The following is a description of a gene set: Mouse Gene Set: GOBP_RRNA_PROCESSING species: Mus musculus Any process involved in the conversion of a primary ribosomal RNA (rRNA) transcript into one or more mature rRNA molecules., and this is the list of marker genes: Rps24, Ddx17, Nop53, Rpl27, Nol8, Trmt112, Mettl16 (methyltransferase 16, N6-methyladenosine), Ddx21, Mrm1, Prkdc, Nhp2, Utp14a, Wdr74, Rpl35, Ddx49, Pop5, Rpp30, Rcl1, Ncl, Emg1, Mrm2, Wdr46, Rpusd1, Dkc1, Zcchc4, Mettl15, Pa2g4, Rps15, Ddx56, Rpp25 (ribonuclease P/MRP 25 subunit), Rexo1, Esf1, Riok3, Wdr12, Dimt1, Mphosph6, Slx9, Tfb1m, Nop14, Rps27, Rps21, Abt1, Rps28, Rpl14, Wdr36, Rpl7l1, Exosc6, Dicer1, Tsr3, Pes1, Tsr1 (TSR1 20S rRNA accumulation), Wdr75 (WD repeat domain 75), Gtf2h5, Eif6, Pdcd11, Znhit3, Rpf2, Rps6-ps4, Heatr1, Rpp38, Utp15, Pwp1, Rps27rt, Wdr3, Ngdn, Rps16, Naf1, Fcf1, Rexo5, Nop9, Exosc8, Nsun4 (NCBI Gene Id 72181), C1d, Ddx51, Imp4, Rpl5, Gtpbp4, Rpf1, Tfb2m, Nop2, Rpp40, Ddx52, Pwp2, Rexo4, Exosc3, Tsr2, Mterf4, Rps25, Myg1, Drosha, Kat2b, Ak6, Mettl5, Exosc5, Npm3, Rpusd4, Isg20, Utp4, Riok1, Nol9, Rrp1, Pop7, Bop1 (NCBI Gene Id 97992), Ddx54, Ftsj3, Rnasel (NCBI Gene Id 353203), Rpusd2, Rps8, Mak16, Sde2, Mphosph10, Utp11, Bud23, Nat10, Fbll1, Riok2, Trmt2b, Bms1, Rps19, Ddx47 (DEAD box helicase 47), Pin4, Exosc1, Wdr55, Nsun5, Wdr43, Chd7 (chromodomain helicase DNA binding protein 7), Eri1, Utp14b, Exosc4, Utp23, Imp3, Utp3, Dis3, Pih1d2, Pak1ip1, Znhit6, Rbfa, Dhx37, Pih1d1, Mtrex, Rrp1b, Rrp9, Ybey, Nsa2, Krr1 (KRR1, small subunit (SSU) processome component, homolog (yeast)), Snu13, Gar1, Mrm3, Rpl11, Nol10, Sart1, Rpl7a, Nob1, Rps14, Rrp7a, Rrp15, Ddx10, Rps17, Utp6, Rrp36, Dcaf13, Exosc10, Lyar, Wdr18 (WD repeat domain 18), Utp25, Ythdf2, Frg1, Ebna1bp2, Cdkn2a, Pelp1, Fdxacb1, Rrp8, Ddx27, Exosc7, Utp18, Rrs1, Nol6, Sirt7, Las1l, Rps7, Nvl, Rpl7, Bysl, Npm1, Nudt16, Urb1, Nsun3, Brix1, Fbl, Nol7, Kri1 (NCBI Gene Id 215194), Exosc9, Wbp11, Ddx18, Rpl26, Rpl35a (NCBI Gene Id 68254, ribosomal protein L35A), Rps6, Srfbp1, Lsm6, Tent4b, Ercc2 (excision repair cross-complementing rodent repair deficiency, complementation group 2), Eif4a3, Sbds, Nol11, Rbm34, Mettl18 (methyltransferase like 18), Pop4, Ppan, Usp36, Nop10, Tbl3, Utp20, Mrto4, Exosc2, Suv39h1